The following is a description of a gene set: species: Homo sapiens Absence of urine, clinically classified as below 50ml/day. Anuria Human Gene Set: HP_ANURIA, and this is the list of marker genes: CFH, AGT, CFI (NCBI Gene Id 3426), AGTR1, C3 (NCBI Gene Id 12266), MYH11, THBD, REN, CFHR3, ACE, CFHR1, CFB, CD46